Given this list of marker genes SERPINE2, MYL9, AMIGO2, DRAIC, COL5A1, CMTM3 (CKLF like MARVEL transmembrane domain containing 3), IGLL3P, ADAMTS1, CD52, BMP2 (bone morphogenetic protein 2), ISLR, SOCS3, ARRDC4, GPR183, COL6A3, LUM, KCNT2, FGFR2, WWC1 (NCBI Gene Id 23286), TIMP2 (TIMP metallopeptidase inhibitor 2), STAT4, MUC13, RGS1, SLPI, HPGD, C9, GEM, PGLYRP2, MXRA5 (matrix remodeling associated 5), RAB27A, GLT1D1, MCUB, TBX15, SEPTIN6, AIM2, THBS2, IL7R, SLC22A15, CCDC80, S100P, SLC2A9, BASP1, LGALS3, COL1A1, CAPG, ERICH5, LXN, MOXD1, HOMER1, CHST11, SLC16A14, MMP9 (matrix metallopeptidase 9), GLIS3, SLC17A9, LURAP1L, SERPINB9, GPR88, RDH12, HABP2, RASGRP1, DUSP5, UGCG, GCH1, TMEM45A, CP, EFEMP1 (EGF containing fibulin extracellular matrix protein 1), MAP3K5 (NCBI Gene Id 4217), COL1A2, GATA6, POU2AF1, COLEC11, IGLV3-25 (NCBI Gene Id 28793), MAL2, FBP1, C15orf48, SEL1L3, CXCL16, VNN1, MYOM1, VNN2, EGR1, TNFSF13B, CXCL12, TNFSF4, PAPLN, ACP5, PRG4, CCL20, EVI2A, ASPN, INHBE, CDA, EPHA1, ASRGL1 (NCBI Gene Id 80150), CRP, CYP2B7P, GDA, SLC15A1, SELENOM, GPNMB, LGALS4, SULF1, GOT1, ETS2, PTGDS, TIMP1, SPHK1, FOXA3, XK, RALGAPA2, MAD1L1, PAG1, SRPX, KCTD12, CYBA (NCBI Gene Id 1535), DCPS, MGLL, ACSL4, SEMA6A, GALNT7, CD24, ZNF83, SLC12A2, CDH1, TPST1, COL3A1, TRNP1, YBX3, SDSL, CCL21, MYO1E, CD2, LSR, GLDC (NCBI Gene Id 2731), NCALD, PELI1 (NCBI Gene Id 57334), C7, HSD17B2, EGR2, RCAN2, SERPINE1, PLBD1, SLC25A18, PLTP, C11orf96, CYP4F22, CYFIP2, ATP2B2, CTHRC1, VCAN, GLS2, BACE2, PKDCC, AEBP1, LOXL1, PMP22, SLC7A2, HAL, MMD, BGN, NAV2, FURIN, KLRB1, TNFAIP8, MCC, RAB27B, CNGA1, CCL19, F3, CYTIP, here is a description of the gene set: Hepatocellular carcinomas represent the third leading cause of cancer-related deaths worldwide. The vast majority of cases arise in the context of chronic liver injury due to hepatitis B virus or hepatitis C virus infection. To identify genetic mechanisms of hepatocarcinogenesis, we characterized copy number alterations and gene expression profiles from the same set of tumors associated with hepatitis C virus. Most tumors harbored 1q gain, 8q gain, or 8p loss, with occasional alterations in 13 additional chromosome arms. In addition to amplifications at 11q13 in 6 of 103 tumors, 4 tumors harbored focal gains at 6p21 incorporating vascular endothelial growth factor A (VEGFA). Fluorescence in situ hybridization on an independent validation set of 210 tumors found 6p21 high-level gains in 14 tumors, as well as 2 tumors with 6p21 amplifications. Strikingly, this locus overlapped with copy gains in 4 of 371 lung adenocarcinomas. Overexpression of VEGFA via 6p21 gain in hepatocellular carcinomas suggested a novel, non-cell-autonomous mechanism of oncogene activation. Hierarchical clustering of gene expression among 91 of these tumors identified five classes, including CTNNB1, proliferation, IFN-related, a novel class defined by polysomy of chromosome 7, and an unannotated class. These class labels were further supported by molecular data; mutations in CTNNB1 were enriched in the CTNNB1 class, whereas insulin-like growth factor I receptor and RPS6 phosphorylation were enriched in the proliferation class. The enrichment of signaling pathway alterations in gene expression classes provides insights on hepatocellular carcinoma pathogenesis. Furthermore, the prevalence of VEGFA high-level gains in multiple tumor types suggests indications for clinical trials of antiangiogenic therapies. studied in species Homo sapiens Human Gene Set: CHIANG_LIVER_CANCER_SUBCLASS_CTNNB1_DN from publication Chiang DY, Villanueva A, Hoshida Y, Peix J, Newell P, Minguez B, LeBlanc AC, Donovan DJ, Thung SN, Solé M, Tovar V, Alsinet C, Ramos AH, Barretina J, Roayaie S, Schwartz M, Waxman S, Bruix J, Mazzaferro V, Ligon AH, Najfeld V, Friedman SL, Sellers WR, Meyerson M, Llovet JM (PMID 18701503) Top 200 marker genes down-regulated in the 'CTNNB1' subclass of hepatocellular carcinoma (HCC); characterized by activated CTNNB1.